The following is a description of a gene set: species: Homo sapiens Human Gene Set: REACTOME_PI3K_AKT_ACTIVATION PI3K/AKT activation, and this is the list of marker genes: PIK3CB, IRS1, PIK3CA, IRS2, PIK3R1, NGF, NTRK1, RHOA, PIK3R2